Given this list of marker genes Mgst3, Gsta3, Ambp, Sesn2, Adh4, Dhfr, Slc22a18, Apoa4, Gsr, Prdx6, Txnrd3, Slc22a1, Aqp9, Ptges, Lpo, Gpx4, Ccs, Selenos, Gsto1, Sod3, Pxdn, Prdx3, Gpx8, Slc39a8, Prdx1, Txn1, Pim1, Gstk1, Sod2, Lancl1, Aldh1a7, Gch1, Abcb1b, Prxl2b, Upk3bl, Fancc, Nos3, Hp (haptoglobin), Slc30a10, Txnrd1, Mpo (NCBI Gene Id 268460), Ralbp1, Rab29, Abcg2, Gpx2, Akr1a1, Cp, Srxn1, Nqo1, Abcc1, Gsto2, Rab40b, Prdx2, Mt2, Slc22a3, Txndc17, Fabp1, Gstm6, Gstt1, Slc47a1, Gstm3, Mgst2, Prkce, Slc30a1, Gstm7, Txnrd2, Aldh1a1, Prdx6b, Prdx5, S100a8, Rdh11, Mtarc2, Kdm3b, Mtarc1, Mt3, Aldh2, Slc11a1 (NCBI Gene Id 18173), Nxn, Prdx4, Fbln5, Selenow, Slc17a3, Aqp8, Tpo, Apoe, Esd, Slc47a2, Trp53inp1, Slc22a2, Sod1, Atp7a, Park7, Adh5, Gpx1, Rdh12, Gpx6, Oscp1, Cat, Nfe2l2, Nnt, Abcc2, Gsta1, Slc29a4, Gstm5, Sesn1, Aifm2, Muc2, Gpx5, Mb, Selenot, Prxl2a, Ptgs1, Apom, Ptgs2, Abcb6, Cygb, Gpx7, Ubiad1, Slc30a3, Epx, S100a9, Abcb1a, Mt4, Cd36, Mt1 (NCBI Gene Id 17748), Gpx3, here is a description of the gene set: Any process that reduces or removes the toxicity of a toxic substance. These may include transport of the toxic substance away from sensitive areas and to compartments or complexes whose purpose is sequestration of the toxic substance. studied in species Mus musculus Mouse Gene Set: GOBP_DETOXIFICATION